The following is a description of a gene set: Mouse Gene Set: MIR_432 from publication Chen Y, Wang X (PMID 31504780) species: Mus musculus Genes predicted to be targets of miRBase v22 microRNA mmu_miR_432 in miRDB v6.0 with MirTarget v4 prediction scores > 80 (high confidence targets)., and this is the list of marker genes: E2f3, Cenpo, Fmnl3, Cpeb2, Pde4a, Zfp825, Ablim1, Mup5, Tbc1d22b, Grk3, Mthfd1, Tln1, Pnisr, Ceacam1, Pbx1, Nqo2, P2rx4, Urgcp, Ceacam2, Ifitm7, Nmrk1, Galns, Celsr2, Nfe2l3 (NCBI Gene Id 18025), Clpp, Fam107b, Mbnl2, Nkiras2, Neurl4, Pik3r3, Kif3c, Tnfsf15, Sertad4, Dnajc14, Shc2 (NCBI Gene Id 216148), Slc13a2, Slc6a6, Foxk1, Bace1 (beta-site APP cleaving enzyme 1), Fam171a1, Psg25, Synj2bp, Adamts18, Tmprss11g, Chsy1, Enam, Tcf15, Nr1d1, Plekhg4, Strn3, H2-Eb2, Csnk1d, Gm5142, Ppara, Nipsnap3b, Rassf2, Ankrd45, Spty2d1, Mup4, Cyp4a32, Emx2, Ormdl2, Ccr1, Kics2, Zfp128, Nipsnap2, Borcs7, Arl5b, Ifnk, Col24a1, Snx27, Clpb, Il7, Col9a3, Orai1, Hmg20a, Pom121l2, Cnksr1, Sema4g, Gykl1, Dnajc6, Pcdh7, Elapor2, Antxr2 (anthrax toxin receptor 2), Cavin2, Spred3, Nfat5, H2-M10.5, Pappa